The following is a description of a gene set: from publication Cui A, Huang T, Li S, Ma A, Pérez JL, Sander C, Keskin DB, Wu CJ, Fraenkel E, Hacohen N (PMID 38057668) Genes negatively differentially expressed in cell type: cDC2 (conventional dendritic cell type 2) upon treatment with cytokine: IL-10 in mouse lymph nodes in vivo. Mouse Gene Set: CUI_CDC2_IL10_RESPONSE_DN studied in species Mus musculus Cytokines mediate cell-cell communication in the immune system and represent important therapeutic targets. A myriad of studies have highlighted their central role in immune function, yet we lack a global view of the cellular responses of each immune cell type to each cytokine. To address this gap, the authors created the Immune Dictionary, a compendium of single-cell transcriptomic profiles of more than 17 immune cell types in response to each of 86 cytokines (>1,400 cytokine-cell type combinations) in mouse lymph nodes in vivo. A cytokine-centric view of the dictionary revealed that most cytokines induce highly cell-type-specific responses. For example, the inflammatory cytokine interleukin-1β induces distinct gene programmes in almost every cell type. A cell-type-centric view of the dictionary identified more than 66 cytokine-driven cellular polarization states across immune cell types, including previously uncharacterized states such as an interleukin-18-induced polyfunctional natural killer cell state., and this is the list of marker genes: Ttc3, Scarb2, Rgs2, Smap2, Nr4a1, Foxp1, Lmo1 (NCBI Gene Id 16908), Fuca1, Jun, Fos, Ucp2 (uncoupling protein 2 (mitochondrial, proton carrier)), Stap1, Npc2, Nedd4, Atf3, Stk38, Klf2, Kctd12, Anxa5, Camkk2, Rnase6, Eif3f, Pmaip1, Sulf2, Rnf166 (NCBI Gene Id 68718), Tep1, Tmem50a, Arl5c, Prcp, Raph1, Mxd4, Irag2, St8sia4, Pid1, Tent5a, Mapk3, Pabpc1, Dusp1, Btg2, Btg1, Celf2, Pnpla7, L1cam, Ypel3, Lmo4, Nsa2, Pold4, Gbp2, Leng8, Pdcd4, Mycbp2, Marveld1, St8sia6, Bri3, Dnajc7 (NCBI Gene Id 67633), H2-DMa, Ubl3, Mcemp1, Eef1a1, Ccrl2, Tsc22d3, Crebrf, Dna2, Gpr141 (G protein-coupled receptor 141), Ncf2, Aph1c, Nadk, Txnip, Arhgap9, Skint3 (NCBI Gene Id 195564), Shtn1, Tsc22d1, Tut4, Ubc, Smim14, Pcbp2 (poly(rC) binding protein 2), Gm2a, Adgre1, Mef2c, Cited2, Cd180 (NCBI Gene Id 268699), Prdx6, Mapk14, Gpi1, Cd33, Spn, Ramp1, Cybb, Ncf1, Samhd1, Eif3e, Dpy19l1, Mdp1, Klhl24, Prrc2b, Ier2, Nfkbiz, Stom, Ccl9 (C-C motif chemokine ligand 9), Crlf3, Eef2, Gsn, Zfp36, Il6ra, Bnip3l, Klf6, Ptpro, Cox7a2l, Nr4a2, Zfp36l2, Gdi2, Ppfia4, Ighm, Rgs10, Neat1, Trappc5, Stk17b, Arsb, N4bp2l1, Fosb, Uba52, Klf4, Hspa1b, Kxd1, Cyp27a1, Sowahc, Egr1, Mbnl1 (NCBI Gene Id 56758)